Given this list of marker genes EFNA4, EPHA1, EFNB3, EFNA3, EPHB2, EPHB6, EPHB1, EPHA10, EPHB3, EPHA8, EPHA4, EPHA6, EPHA7, EPHA3, EPHA5, here is a description of the gene set: Combining with a transmembrane ephrin to initiate a change in cell activity. studied in species Homo sapiens Human Gene Set: GOMF_TRANSMEMBRANE_EPHRIN_RECEPTOR_ACTIVITY